Given this list of marker genes PIAS2, PPFIA4, MAPK3, TSPAN32, NDUFS3, DAP, SLC38A10, TENT5C, ACOX1, CDC42SE1, TMEM37, GOLGA3, LRP1, JOSD2, PNKP, XRCC1, ALDH3A2, MZT2B, PSMB6, TMEM126A, CD93, SEC61B, NSMCE4A, TUBB2A, RPL3, ANAPC11 (anaphase promoting complex subunit 11), SESN1, DIP2B, SDHB, ZFYVE19, STMP1, APOBEC1, PRPF31 (NCBI Gene Id 6106), TYMP, ABL1, REEP5, RGL2, SPSB2, ARRB1, SRPK2, MXD4, OGDH, ACSS1, CPT1A, CASP9, PLEKHO1, NFIC, RASA3, RERE, SLC4A8, DDX39B, PKIG, SARAF, COMMD4, RAB4A, CDK2AP2, CSNK1G2, RING1, ASNSD1, EPRS1, GGA2, PROC, COL13A1, FOXO3, ARHGAP9, EIF3K, ZFAND2A, TEP1, PTOV1, HSD17B11, ATP6V0D1, ADD1, AP1B1, MKNK2, DBP, UBE4B, SLC50A1, VPS37B, MAT2B, NBR1, DBNDD2, C9orf78, PIGX, WIPI2, MRTFA, ATM, C1QB, PAFAH1B3, RPL28, CERK, SGK1, IMP3, RGS2, VAMP8, YPEL3, SNX12, CXCR4, SRP9, RNF220, EIF4EBP2, RCAN3, DFFA, TEN1, TPGS1, ECHS1, RPL19, GTF3C1, HFE, LEPROT, RSU1 (NCBI Gene Id 6251), CLTA, COLGALT1, RIT1, PRPF6, SAMM50, ATP6V0A2, TMEM223, LEMD2, FNTA, TFIP11, TNFRSF21, UQCRC1, HLA-DMA, UBALD2, NCBP2AS2, RBCK1, CLN8, CBX4, STX2 (NCBI Gene Id 6808), EPC1, TALDO1, NDUFB9, HRAS, RAD50, XAB2, MCM10, ING4, PPP1R21, PCBD2, CDCA7L, RPS5, SLC27A1, MRAS, TBC1D22A, MAST3, PAQR7, GUK1, TMEM179B, ATP6V1D, CDT1, FES, SIRT3, TRIM47, PTPN18, CD99, CMTM8, LYL1, RIMOC1, ST6GAL1, GNA12, RPS6KB2, WDR81, NME4, PEX11B, MRPS25 (NCBI Gene Id 64950), ULK1, SCAMP2, FRAT1, AKT1, CSK, ECH1, NELFE, INTS3, SEC14L1, PTCD2, WASHC2A, CFAP20, DAGLB, NME6, SUPT4H1, NME3, FLCN, NDUFA8, ATP5PO, OTULINL (NCBI Gene Id 54491), KANK3, GNAS, NICN1, IDH2, LAT2, TLE5, GRN, LSR, GTF2H4, ILK, ORC5, MAN2B1, SLC35A1, GLB1, CLN6, here is a description of the gene set: Genes down-regulated in T reg: peripheral lymph nodes versus thymic CD24 high. We investigated at which stage of maturation commitment to a stable Foxp3-expressing phenotype takes place. We assessed stability of Foxp3 expression in thymic Foxp3+ Treg subsets of different maturity, defined by CD24 expression. Next we compared gene expression profiles of Foxp3+ Treg subsets (+) of different maturity (24lo, 24int, 24hi) and could identify a set of genes that were specifically up or downregulated in Foxp3+ Tregs, but not in Foxp3- conventional T cells, in a maturation-dependent manner. Human Gene Set: GSE42021_TREG_PLN_VS_CD24HI_TREG_THYMUS_DN from publication Toker A, Engelbert D, Garg G, Polansky JK, Floess S, Miyao T, Baron U, Düber S, Geffers R, Giehr P, Schallenberg S, Kretschmer K, Olek S, Walter J, Weiss S, Hori S, Hamann A, Huehn J (PMID 23420886) studied in species Homo sapiens